The following is a description of a gene set: Any process that results in a change in state or activity of a cell (in terms of movement, secretion, enzyme production, gene expression, etc.) as a result of an oxygen-containing compound stimulus. species: Homo sapiens Human Gene Set: GOBP_CELLULAR_RESPONSE_TO_OXYGEN_CONTAINING_COMPOUND, and this is the list of marker genes: FZD10, RAB31, PPP5C, DRD1, RPS6KB2, DEFA1B, SERPINA12, CDK19, NONO, PCK2, IRAK2, DEFB104B, CD4, MAT2A, PDCD1LG2, ANKZF1, SERPINF1, GPR27, PPARA, ADCY8, RHOB, BNIP3, RPS6, MAP2K3, DEFB104A, GNAL, TLR6, AQP8, DGKQ, ACACA, OPRK1, ABCA1, NFKBIB, MLXIPL, MIR133A1, CUL3, WNT9B, TRIM72, PCSK9, TBX1, KCNE1, TRAF6, RIPK1, CRTC3, RGS10, IRF8, GLRA1, SLC7A5, RPTOR, INPP5K, SSH1, JAGN1, CRYGD, ADCY2 (adenylate cyclase 2), GATA1, SMARCA4, LPIN2, MMP8, MAS1, FYN, ZFAND1, SOX10, ABL2, GDAP1, AGRN, PIK3CG, GOT1, APLP1, ZNF683, TSHR, CMPK2, SYAP1, NCSTN, GHRHR, CYGB, CD40, EGR1, SIRPA, CHRNE, ERRFI1, ATP5PO, TYROBP, UBR1, EPHA5, PRKDC, PLA2G6, RPL23, LRP6, MTR, WNT1, EIF4A3, SNX5, GBP5, VWA2, HTR2A, IL1A, PLCG2, COMT, PDGFB, ADRB2, GJB6, ADRA2A, PTPRN2, MIR320B2, TREX1, UNC13B, WNT11, SLC8A1, AQP2, NCOA4, CACNA2D1, HTR3E, G6PC1, MGARP, KIF18A, CALCRL, TRERF1, SLC23A2, GRK2, MTDH, GNAI2, GNAO1, OSER1, JAK3, GNG2, MIR15A, CYP11B1, FBXW8, TAF1, KANK2, PDX1, SPI1, APPL2, NPPC, SOS1, SOCS2, SBNO2, OSBPL7, CLEC7A, GNA14, FOXC2, IL24, GH1, RGS9, AKR1B10, PDE2A, KLRK1, UBTF (upstream binding transcription factor), SLC12A6, NR1D1, WNT10B, SPHK1, CD80, WT1, ITGA4, AKR1A1, UBR2, NOS3, ANKRD13C, GBP3, HMGB1, WNT6, OSR1, MAPK9, GUCY1B1, ARHGEF2, SLC27A1, C2CD5, PF4, SLC26A3, CDH1, FER, DHFR, JAK1, LARS1, PARK7 (Parkinsonism associated deglycase), CAV1, CHRNB3, CCR7, CHEK2, HDAC9, TRARG1, HTR3C, SFRP1, GCLM, HAND2 (NCBI Gene Id 9464), PTGDR, PDE4D, BRSK2, LRRK2 (NCBI Gene Id 399472), PALM, EEF2K, BRINP2 (NCBI Gene Id 57795), PHOX2B, FUT7, WNT3, PTGER4, CCL28, GH2, ENDOG, ZBED6, HPCA, PCNA, DRD5, FKBP1B, STK25, LBP, ABCB4, GPR21, FZD4, PEX14, LARGE1, KAT2B, NQO1, CHRND, EPHA4, PDCD4, APOA4, GPX1, SLC6A4, PLA2G2A, TNFAIP3, LPAR1, CDC6, CYP27B1, CXCL10, MIR128-1, MTCL2, HIF1A, FPR2, NR3C1, MIR17, TIMELESS, BTK, SIN3A, LDOC1, SMARCB1, GRAMD1B, TET1, TEAD2, TP53INP1, SLC26A6, CD55, HDAC6, ADCY3, GNRHR2, PKLR, CXCL6 (NCBI Gene Id 6372), MIR140 (NCBI Gene Id 406932), CRKL, IRS4, BMP6, MIR320E, CCNA2, GRAMD1A, BAIAP2, CRHBP, TRPM4, WNT8B, INSIG2, NCOA2, MIR125B1, LYNX1, HCN1, UMODL1, SULT1A3, CLDN1, MYO5A, FBLN5, PRPF8, CPS1, ANKK1, PTK2, SGK1, PCK1 (phosphoenolpyruvate carboxykinase 1), SOX4, CTNNA1, SRF, HTR2B, RIPK3, STC1, RORA, MIRLET7B, P2RX3, ATP1A3, STAT1, SIPA1, ROCK2, NPPA, CASTOR2, FOXO1, ADCY7, FBP1, AHR, RXRA, MIR92A1, BPI, SYK, AMBP, NOX4, CPEB1, CSH2, MAP1LC3A, ATP2B1, ROCK1, CES1, NLRP3, SMAD4, ENY2, AGTR1, SCNN1A, FOXO3, PTPRJ, SLIT2, DRD4, FGFR2, EPRS1, DYNLL1, LY96, ALDH1A1, IL37, RAPGEF1, NFE2L2, LEP, SLC2A4 (solute carrier family 2 member 4), MAP3K7, EDN1, HES1, CD36, ADPRS, PABPN1, PPBP, MET, PHIP, CASP7, FECH, CHRNB2, MIR1271, CRHR1, GIT1, CYP11A1, TRAF2, AQP9, MMP9, CEBPE, SNW1, PPEF2, MAP2K7, CUL7, GRIA1, VDR, STRA8, ACOD1, TLR4, PTGDR2, PTK7, ERN1 (endoplasmic reticulum to nucleus signaling 1), JUND, SIDT2, ITPR2, SLC30A10, P2RX4, CERS1, MIR320D2, RAPGEF3, MALT1, ARRB2, AXIN2, IRF3, CX3CL1, INSIG1, NDUFA13, GAB1, RARG, CCDC186, CREB1, B2M, ZNF592, FGF23, AGER, C1QTNF12, IL1B, LITAF, PIK3R1, IL6, PRKAA2, PTGER1, MIR15B, DDR2, TRIB3, HRH4, LTK, RARA, KCNK4, TWF2, PPP1R1B, PAK1, TRPM5, PTGER2, GPR37L1, P2RY11, UGT3A2, PIK3C2A, PAF1, MAPK14, HSF1, STAT5A, MIR342, UCP2, P2RY1, RXRB, ZNF703, SHPK, MIR143, BLM, CFLAR, DEFB118, MIR187, ADAMTS13, CHRM1, DNAI1, NCK1, GPRIN3, SLC8A3, GRB2, PTCH1, CD180, DEFA1, EZH2, TNIP1, IL18, CMA1, PTK2B, PIP4K2C, RAB11B (RAB11B, member RAS oncogene family), GHRL, CACNB1, RANGAP1, WNT7B, EIF4E, KCNK2, CEBPB, CHRNA1, DNMT1, ATP5F1A, PEX2, CBX3, CAMP, CARD8, RAB8A, LEPROTL1, SLC22A12, USF1, BCR, KDM6B, BAD, PIM3, CSF2, SMARCD1, SIX1 (NCBI Gene Id 6495), BMI1, SOX9, GRM5, RDH12, GPER1, PXN, SELENOT, FOXP1, SPIDR, AKAP7 (NCBI Gene Id 9465), CYP24A1, TRIM5, RUVBL2, ZNF236, MPV17, PARP1, CASTOR3P, P2RY4, PKM, VSNL1, CD14, WNT3A, BRINP1, POSTN, POU4F2, CDK4, INHBB, FFAR2, WDTC1, AHCYL1, NFKBIL1, TNC, COL6A1, ID3, PDK4 (pyruvate dehydrogenase kinase 4), ALAS1, TRPA1, MBD5, AIFM1, ACHE, LEPROT, NKX6-1, CARD17P, ADCY6 (NCBI Gene Id 23320), PRDX5, GRAMD1C, ZNF277, CHRNA4, PRMT1, AR, SLC1A2, ABCC9, DMTN, NOD2, SHOC2, PLSCR3, TICAM2, PKD2, TUNAR, SMO, LGMN, MIR107, GRB10, NCL, BRINP3, SLC5A5, MAPK3, TRPV1, CSHL1, XBP1, FAM210B, SELENOS, CAMK2A, CASR (calcium sensing receptor), SYBU, HTR1A, MAPK13, RELA, CHRNG, ESR1, PDE4B, ENPP1, PID1, PIH1D1, LCOR, SMAD3, ZC3H12A (zinc finger CCCH-type containing 12A), TNFRSF1B, IGF1, AQP1, SESN3, MIRLET7G, CSF2RA, C2CD2L, CFL1, APPL1, LY6S, SCNN1B, ITGB3, ERCC6L2, ZNF35, GPLD1, GFI1, NR1H4, MAP1B, OXCT1, HTR3D, ATM, LY86, SOCS1, KCNC2, HADHB, ESD, TSC2, NPTX1 (NCBI Gene Id 4884), AKR1C4, MYO1C, CAV2, GKAP1 (NCBI Gene Id 80318), CDK16, CD86, TOP2B, FDX1, IRAK3, NHERF1, LILRB2, SMYD3, ZBTB20, KAT5, MIR766, DTNBP1 (dystrobrevin binding protein 1), GPR155, RORC, CACNA1A, DHFRP1, TMIGD1 (transmembrane and immunoglobulin domain containing 1), SMARCC1, LIN28A, FOLR2, VIM (vimentin), VPS35, DENND4C, AKT2, HTR4, ZNF580, SLC1A3, MPC2, MIRLET7F1, MIR103A1, ABL1 (ABL proto-oncogene 1, non-receptor tyrosine kinase), PLCB1, MIR320B1, MIR20A, NR4A1, RARRES2, PDE8B, DEFA4, PSEN1, GCK, HMGB2, AGTR2, KMO, CTNNB1, LRP8, SPON2, AKR1C2, JAK2, PIK3R3, LTF, MIR320D1, BLVRB, CHRNA10, NADK, COL1A1, GLP1R, USP8, RBX1, EFNB2, DAG1, PIK3R2, LONP1, RAMP3, LY6G6D, NGFR, CCL2, STAMBPL1, RAF1, ADAM9, KLF7, P2RY2, NTRK3, VAMP2, EGFR, E2F1, VCP, SERPINE1, MZB1, SREBF1, ABCB1, AKR1C1, NTRK1, CASTOR1, EPHB2, PRKCZ, TLR9 (toll like receptor 9), DAB2IP, GNB1, ZFP36L1, NET1, ALDH1A2, SRC (NCBI Gene Id 6714), KLHL22, TNIP3, DEFA3, PRDX1, PRKN, FES, IL36G, SGCB, LPL, IL1F10, FOLR1, HTR6, MSX2, IGFBP5, RFX6, PEX13, AMIGO1, DAPK1, VCAM1, MIR145, NPR2, AKAP6, ESR2, PINK1, SHMT1, BCL11A (BCL11 transcription factor A), GLRA2, CDK2, NME8, PLEKHA1, TPM1, LCN2, MTOR, CHRM4, KDM1A, PDGFRA, CYP26B1, GPR68, ZNF16, NUGGC, APC, NDUFAF2, BACE1, CSH1, PHPT1, PRKAR1A, TREM2, LRP1, CASP1, INS, AKAP8, STX4 (NCBI Gene Id 6810), CAPN10, EHMT2, ATP7A, CPEB2, SESN2, TBX2, LPIN3, OPRM1, HDAC5, CD68, AGT, SASH1, BAIAP3, CD200, NR1H3, FCAR, EPHA3, MRC1, NR4A2, POR (NCBI Gene Id 96440), GJA1, CHRNA9, ZDHHC7, MIR320C2, H2AZ1, RAC1, TESC, KLRC4-KLRK1, MAPK7, PTPN22, OGT, KCNB1, MB, AVPR1A, KANK1, LANCL2, GAS6 (NCBI Gene Id 2621), EP300, CDK1, ZFP36, LRP5, STAP1, IGF2, CYP7A1 (NCBI Gene Id 1581), HRAS, ITGA2, PAX2, ADIPOR1, PRKCB, FAT1, CHRNB1, ADCY5, MPO, FIS1, RACK1, RET (NCBI Gene Id 5979), HTR7, CCNB1, DNMT3A, PDE3B, CHRM5, RPS6KB1, CCL21, TRIM41, STXBP4, USF2, MIR185, GHR, RWDD1, HGF, KCNQ1, CTSD, FFAR3, RAPGEF2, ROMO1, DDX18, GHSR, PLSCR4, PDCD10, CXCL5, GPRC6A, PCGF2, GSTP1, TRAP1, PJVK, AXL, PRKCI, CDK5R1, SHC1, INSR, SRSF5, MAPT, DDIT4, PLAA, CHRNA3, LHCGR, YES1, BCL10, LYN, NAMPT, PEX5, RAB10, PTPRN, NFE2L1, FXN, PNPLA3, ECT2, TIFAB, CRHR2, TP53, METTL21C, RORB, MAPKAP1, GNA15, MYD88, MIR200A, ATP2B4, DGAT2, PPARG, ELK1, ACTB, YAP1, MAP3K5, PRKCA, CYP11B2, RHOQ, NCOA5, SPP1, PTPN11, DEFB131A, CRTC2, ANO1, CD6, MSN, IRGM, PLEC, PPP3CB, SIGIRR, CRTC1, MIR320A, MIR224, TXN, CASP9, NOS2, PSCA, PRDX3, DEFA6, ZNF106, AHSG, TRA2B, RIPK2, NCOA3, ADIPOQ (adiponectin, C1Q and collagen domain containing), GNAQ, SLC38A2, FOXO4, OXR1, BRCA1, PYCARD, CTSG, CACNA2D3, NRIP1, CRK (NCBI Gene Id 1398), SORBS1, LY6E, AFG3L2, HTR3B (NCBI Gene Id 9177), CYBA, ACE, LILRB1, SLC39A9, TBC1D4, GNAS, INHBA, CXCL9, RDH11, PTPRK, CHRNA7, DEFB114, CCL19, AP3S1, MYOG, MIR98, CHRNA5, GRIN2D, CA2, UCP1, BCAR1, IRF5, NPAS4, CAV3, HAVCR2, CCS, FZD7, PENK, IL18BP, PPP3CA, STAT5B, NOD1, ARID5A, SULT1A4, TGFB1, CCR5, SCNN1D, MYB, MGST1, PRKACA, CIB2, SLC2A2, GNAI1, MIR337, GSK3A, MAPK1, SLC27A4, HTRA2, CDKN2A, BGLAP, SCARB1, PDK3, SSTR1, DRD3, PIP4K2A, MIR182, WNT9A, PAWR, LARP1, HLA-DRB1, MDM2, SCNN1G, NLRP7, ITPR1, HCN2, NCF1 (neutrophil cytosolic factor 1), CFTR, CHRNA2, MAP2K4, FUT1, ECHDC3, ALK, HTR3A, GATA4, MMP3, AKT1, AGAP3, STAT6, NFKBIA, CEACAM1, LILRA2, YWHAG, SRI, SCX, EDNRB, CAT, EDNRA, CDK5, CSRP3, CARD16, FBXO32, DHX36, SORL1, GCH1, WNT5A, PLA2G1B, CYBB, IRS2, NR4A3, NUCKS1, SLC29A1, GCG, PTK6, KLF4 (NCBI Gene Id 9314), MIR21, CXCL8, HNRNPD, FCGR2B, TIRAP, ABCC1, SAMTOR, IDE, GRB7, UPF1, IL12B, TNFSF4, HCN4, CDC73, WNT2, MIR223, CD274, SMPD3 (sphingomyelin phosphodiesterase 3), SOD3, LDLR, JUP, SOCS7, EIF4EBP2, RAP1GDS1, ADH4, SOCS3, CPT1A, KLF2, PTAFR, CX3CR1, GCLC, MIR146A, RGS4, NCOA1, TOP1, EZR, MT3, IP6K2, GNA11, FABP1, CHRM2, RPS3, IRAK1 (interleukin 1 receptor associated kinase 1), SH2B2, NDEL1, SLC12A7, CBX8, PIP4K2B, MEIOSIN, PRKCE, CACTIN, PTPN1, STAT3, RPS6KA2, DPEP1, AKAP9, HMGCS2, PHC1, CXCL13, FLNA, TRIM24, SLC2A5, RAD51, PTPRE, PDXP (pyridoxal phosphatase), TLR2, RAP1BL, DYNAP, BTG2, RAP1B, KLF9, FBN1 (fibrillin 1), AKR1C3, NFKBIZ, ZBTB7B, TNF, INSRR, POU4F1, BCAR3, PPM1E, USO1, HTR2C, RAB11FIP5, TYK2, SLC2A8, SCIMP, SETX, TSPO, TBXA2R, RAB13, CHRNA6, IL18RAP, CAMKK2, MAPK8, PDPK1, DEFA5, MMP2, AGTRAP, GRB14, RHOA, OR51E2, MED1, CYP1B1, HCN3, SLC39A14, SOD1, LACRT, GPR37, HRH3, HCK, DEFB124, CCDC62, MIR433, RECQL5, OTOP1, SLC9B2, MIR6869, SNAI2, PDE3A (phosphodiesterase 3A), PIK3CA, RYR3, ABCA12, SLURP2, IL10 (NCBI Gene Id 3586), LY6H, RGS8, AANAT, P2RY12, NFKB1, SOS2, MSTN, TNS2, EFNA5, CHRNB4, OGG1, SRD5A1, GOLPH3, FAM114A1, GNB5, TLR5, SIRT1, VPS54, PRKD1, GPR173, ABCC8, PRNP, IL36RN, TRPC6, GPD1, MLC1, PIM1, SNRNP70, CHRM3, HOXA2, PF4V1, MEF2C, GRIN1, CCL27, OSBPL8, GBP2, P2RX7, IGF1R, HNF4A, OSBP, ADAM15 (ADAM metallopeptidase domain 15), KCNK16, SLC9A1, PEX10, MIR106B, MIR96, RAP1A, PDK2, GNRHR, PPIF, KCNK10 (NCBI Gene Id 54430), CSF3, CHMP5, HDAC2, GDF15 (growth differentiation factor 15), PTPN6, MIR195, BECN1, SSTR2, MN1, PRMT5, IL36B, TRPM2, XPO1, IGFBP1, TRIB1 (tribbles pseudokinase 1), SESN1, MAP4K1, AICDA, BMP7, PEX12, APP, PPARD, CASP4, GSK3B (glycogen synthase kinase 3 beta), TNIP2, RB1, ICAM1, DRD2, CSK, MIR16-1, SOD2 (superoxide dismutase 2, NCBI Gene Id 79099), COLEC12, PPP1R9B, FOXA2, IL36A, SIK2, PRKAA1, RAB11FIP2, ERFE, SNX6, PRKCD, CRH, PTGFR, IRAK4, SP1, GCGR, PTPN2, PRDX2, CCL7, FOS, IRS1, PDGFD, ACTN2, RRAGD, SLC25A33, RBM4, CTR9, PRKCQ, GATA5, WNT5B, MYOD1, ANKRD1, SLC1A1, CLTRN, HSP90B1, MIR34A, GRIN2A, C14orf28, ASS1, DDX11, LPIN1, SPHK2, TFAP4, P2RY6, KLF16 (KLF transcription factor 16), CAPN2, XRN1, GPBAR1, TGM2, MIR320C1, MIF, TICAM1, PHEX, ADCY1, KBTBD2, ADH5, GLP2R, LYPD1